The following is a description of a gene set: studied in species Homo sapiens Genes having at least one occurence of the motif AGCGCAG in their 3' untranslated region. The motif represents putative target (that is, seed match) of human mature miRNA hsa-miR-191* (v7.1 miRBase). Human Gene Set: AGCGCAG_MIR191, and this is the list of marker genes: EGR3, MAGI1, ETF1, HMGB1, DIO3, CCM2L, CHRD, RC3H1, CCDC88B, SPEN, OGT, SNRNP70, UBAP2